The following is a description of a gene set: Catalysis of the reaction: H2O + sphingomyelin = ceramide + choline phosphate + H+. Human Gene Set: GOMF_SPHINGOMYELIN_PHOSPHODIESTERASE_ACTIVITY studied in species Homo sapiens, and this is the list of marker genes: SMPD3, SMPD4, SMPD2, STX4, SMPDL3B, ENPP7, SMPDL3A, SMPD1